Given this list of marker genes Gria1, Them4, Adora2a, Atp2b2, Gabrg2, Map2, Ngfr, Kcnh1, Adora1, Akap5, Gabra3, Hip1r, Stx4a, Ptprk, Kcnb1, Kcnc1, Plek2, Cib1, Inpp5j, Kcnc2, Gria2, Mapk8ip3, Pak1, Vasp, Adgrv1, Kank1, Cspg4, Hcn1, Dock8, Psd4, Wls, Atf4, Fgr, Tesc, Sh3bgrl3, Diaph1, Slc39a6, Fermt2, Sptbn1 (spectrin beta, non-erythrocytic 1), Cacna1d, Shisa8, Sgce, Gabrg3, Amph, Kcnn4, Oprd1, Myo1c, Apc2, Dlc1, Itgb3, Itgav, Twf1, Thy1, Robo1, Palm, Synj2, Tirap, Cd44, Fgd2, Spry4, Arhgap45, Pip5k1c, Bmx, Dnm2, Cacng8, Arf4, Fam107a, Arhgef2, Shisa9, Gper1, Eps8l1, Psd, Eps8l2, Trpc2, Gabra6, Adgre5, Mtmr6, Tiam1, Atp6ap2, Shisa6, Adam17, Ddn, Ripor2, Sh3yl1, Clasp2 (CLIP associating protein 2), Chrna7, Itga8, Epha2, Grin2a, Cfl1, Plekha1, Grin1, Nckap1, Abca7, Macf1, Scimp, Ank1, Aif1, Fgd5, Reg1, Atp2b1, Epb41l5, Ksr1, Hpca, Plcg1, Slc9a5, Tacr3, Vezt, Itgb1, Antxr1, Pdxp, Insr, Wwc1, Cdc37, Cdkl5, Trpv4, Arhgap44, Unc5a, Dpp4, Pla2g4f, Cntnap2, Gabbr1, Myo1d, Fermt1, Pip5k1a, Rasgrp2 (RAS, guanyl releasing protein 2), Nradd, Eef1a1, Oprm1, Gabra2, Pdpn, Jcad, Tln1, Kcnj11, Coro1c, Hcn2, Mtmr9, Psd2, Lcp1, Fap, Rps3, Kcna2, Cdc42, Gabra4, Egfr, Lamp5, Gabra5, Erbb2, Mpp2, Sh2d3c, Myo6, Itga5, Spata13, Plekho1, Clcn2, Rigi, Trpv1, Appl2, Robo2, Arpc2, Rhoa, Nme1, Gabra1, C2cd5, Src, Slc12a5, Epb41l3, Sntg1, Ppp1r9b, Piezo1, Plxnd1, Pacsin2, Syne2, Kcnc4, Ush2a, Mtss2 (MTSS I-BAR domain containing 2), Slc1a2, Pde9a, Clrn2, Ptprj, Mcoln3, Shisa7, Plek, Ptprz1, Rac1 (NCBI Gene Id 52352), Eps8l3, Akt2, Dagla, Gabarapl1, Ezr, Apc, Plcg2, Psd3, Inpp5k (inositol polyphosphate 5-phosphatase K), Gabre, Pkhd1l1, Myo1g, Eps8, Pacsin1, Mapt, Gabrg1, Tpm1, Aif1l, Kcnc3, Spry2, here is a description of the gene set: The portion of the plasma membrane surrounding the leading edge of a motile cell. Mouse Gene Set: GOCC_LEADING_EDGE_MEMBRANE species: Mus musculus